Given this list of marker genes Copb1, Tmed3, Copg1, Copb2, Copa, Scyl1, Dipk2a, Cope, Copg2, Copz2, Arcn1, Copz1, here is a description of the gene set: studied in species Mus musculus One of two multimeric complexes that forms a membrane vesicle coat. The mammalian COPI subunits are called alpha-, beta-, beta'-, gamma-, delta-, epsilon- and zeta-COP. Vesicles with COPI coats are found associated with Golgi membranes at steady state. Mouse Gene Set: GOCC_COPI_VESICLE_COAT